Given this list of marker genes PSMB7, PSMD7, PSMD3, PSMC6, PSMB6, PSMD8, PSMD13, PSMD4, PSMA1 (NCBI Gene Id 5682), PSMA8, PSMA7, UBA52, PSMC3, PSMC2, PSMD14, PSMB5, PSMA4, PSMB4, PSMB3, PSMD12, PSMA6, PSMD11 (proteasome 26S subunit, non-ATPase 11), UBC, SEM1, PSMC5, PSMA5, DERL1, PSMD1, RPS27A, PSMD6, PSMB1 (proteasome 20S subunit beta 1), PSMC4, PSMB2, PSMD2, ADRM1, PSMD9 (NCBI Gene Id 5715), PSMA3, SOD1, UBB, PSMC1, PSMA2, here is a description of the gene set: Pathway Definition from KEGG: SOD1* -| DERL1 -> (Protein+UB) -- 26S -> Peptide Mutation-caused aberrant SOD1 to 26S proteasome-mediated protein degradation. Pathway ID: N01144. Pathway type: Variant. Pathway class: nt06464 Amyotrophic lateral sclerosis. studied in species Homo sapiens Human Gene Set: KEGG_MEDICUS_VARIANT_MUTATION_CAUSED_ABERRANT_SOD1_TO_26S_PROTEASOME_MEDIATED_PROTEIN_DEGRADATION